The following is a description of a gene set: from publication Cui A, Huang T, Li S, Ma A, Pérez JL, Sander C, Keskin DB, Wu CJ, Fraenkel E, Hacohen N (PMID 38057668) species: Mus musculus Cytokines mediate cell-cell communication in the immune system and represent important therapeutic targets. A myriad of studies have highlighted their central role in immune function, yet we lack a global view of the cellular responses of each immune cell type to each cytokine. To address this gap, the authors created the Immune Dictionary, a compendium of single-cell transcriptomic profiles of more than 17 immune cell types in response to each of 86 cytokines (>1,400 cytokine-cell type combinations) in mouse lymph nodes in vivo. A cytokine-centric view of the dictionary revealed that most cytokines induce highly cell-type-specific responses. For example, the inflammatory cytokine interleukin-1β induces distinct gene programmes in almost every cell type. A cell-type-centric view of the dictionary identified more than 66 cytokine-driven cellular polarization states across immune cell types, including previously uncharacterized states such as an interleukin-18-induced polyfunctional natural killer cell state. Genes negatively differentially expressed in cell type: CD8+ T cell upon treatment with cytokine: IFN-β in mouse lymph nodes in vivo. Mouse Gene Set: CUI_T_CELL_CD8_IFNB_RESPONSE_DN, and this is the list of marker genes: Btg2, Pdcd4, Septin6, Cd52, Jakmip1, Tcf7, Mknk2, Pou2f2, Ahnak, Gnai2, Ypel3, Rp9, Tubb5, Supt4a, Atp1b3, Cited2 (Cbp/p300-interacting transactivator, with Glu/Asp-rich carboxy-terminal domain, 2), Ucp2, Chd4, Smad7, Pbxip1, Uba52, Rabac1, Cmah, Cdkn1b, Txnip, Sh3kbp1, Stim1, Madd, Dusp2, Ube2h, Cdk2ap2, Sh3bgrl3, Myl6, Rflnb, Mxd4, Hmgb1, Rgcc, Lef1 (lymphoid enhancer binding factor 1), Kif21b, Pcmtd1, Cd3g, H2az1, Tacc1, Gramd1a, Tagln2, Grap, Klf6 (NCBI Gene Id 97911), Arhgdib, Git2, Ostf1 (osteoclast stimulating factor 1), Cyb5a, Hdac7, Ralbp1, Bnip3l, Plec, Lasp1, Fth1, Themis, Emp3, Sgk1, H2az2, Otulinl, Lbh, Ccr9, Tsc22d3, Smc6, Ctla2a, Txk, Crip1, Gimap6, Ctsd, Itgb7, Gimap3, Anp32a, Gpsm3, Calm2, Ttc3, Reep5, Clk1, Sh2d1a (NCBI Gene Id 279676), Actn1, Gpx1, Tecpr1, Stk38, Fos (FBJ osteosarcoma oncogene), Chd3, Hmgb2, Bcl9l, Stk4, Sorl1, Ppp1ca, Acp5, Cyba, Spn, Cd5, S100a13, Pnrc1, Arhgef18, Retreg1, Dapl1 (NCBI Gene Id 76747), Golm1, Vim, Myh9, Top2b, Ankrd44, Smc4, Tuba1a, Peak1, Zdhhc20, Pglyrp1, Adgre5, Rasgrp2, Cd7, S100a6, Thy1, Klf2, Selplg, Ifngr1, Cnn2, Kmt2e, Plcxd2, Nlrc3, Cotl1, Gmfg (NCBI Gene Id 80485), Klrd1, Rac2, Anxa5, Srpk2, Rgs10, Ssbp3, Scp2 (sterol carrier protein 2, liver), Gm2a, Fyb1, Ogt, Zmiz1, Gtf2i, Luc7l2, Pnisr, Neurl3, Itga4, Flna, Rassf2, Iqgap1, Ankrd12 (ankyrin repeat domain 12), Dap, Bin2, Grk2, Ets1, Zyx, Gpx4, Ramp1, Entrep3, Fam78a, Ccdc88c, Hvcn1, Ing1, Septin9, Fxyd5, Hnrnpa1, Jak1, Klf3, Add3, S100a10, S1pr1, Zfp36l2, H2aj, Lgals1, Pik3r1, Cyth4, Actg1, Ppp2r5a, Tle5, Bin1, Adcy7, Tbc1d10c, Klhl24, Laptm5, Ftl1, Il7r, Arl5c, Fmnl1, Pik3ip1